The following is a description of a gene set: studied in species Mus musculus Mouse Gene Set: GOBP_VESTIBULOCOCHLEAR_NERVE_MORPHOGENESIS The process in which the anatomical structure of the vestibulocochlear nerve is generated and organized. This sensory nerve innervates the membranous labyrinth of the inner ear. The vestibular branch innervates the vestibular apparatus that senses head position changes relative to gravity. The auditory branch innervates the cochlear duct, which is connected to the three bony ossicles which transduce sound waves into fluid movement in the cochlea., and this is the list of marker genes: Nrp2, Tifab, Pax2, Neurog1, Atp8b1, Nrp1